The following is a description of a gene set: species: Homo sapiens Intra-Golgi traffic Human Gene Set: REACTOME_INTRA_GOLGI_TRAFFIC, and this is the list of marker genes: VTI1A, CYTH1, GOSR2, RAB41, GOLIM4, RAB36, COG2, MAN1A2, RAB33B, COG7, BET1L, STX16, CUX1, CYTH3, NAPG, COG4, GOLGA5, TRIP11, MAN1A1, MAN1C1, STX6, VPS45, GOSR1 (golgi SNAP receptor complex member 1), RIC1, ARF1, SNAP29, COG3, STX5, CYTH4, COG6, RAB30, RGP1, YKT6, CYTH2, RAB39A, COG1, NSF, COG8, NAPA, MAN2A2, COG5, ALPP (NCBI Gene Id 250), NAPB, MAN2A1